Given this list of marker genes PRKAR1B, PRKCA, PRKACB, ADCY2, GRK2, PRKAR2A, CALM1, PRKX, PRKCD, ITPR2 (inositol 1,4,5-trisphosphate receptor type 2), CREB1, PRKAR2B, CAMK2A, CAMKK2, ITPR3, PDE1C, PRKACG, CAMK4, KPNA2, ADCY3, ADCY4, PLCG1, PRKCE, ADCY7, NBEA, ADCY1, AHCYL1, CAMK2G, ADCY9, PDE1B (phosphodiesterase 1B), PRKACA, ADCY8, CAMK2B, PRKAR1A, ADCY5, ADCY6, PRKCG, CAMK2D, PDE1A, ITPR1, CAMKK1, here is a description of the gene set: Reactome Pathway: DAG and IP3 signaling part of: Intracellular signaling by second messengers This pathway describes the generation of DAG and IP3 by the PLCgamma-mediated hydrolysis of PIP2 and the subsequent downstream signaling events. studied in species Homo sapiens